The following is a description of a gene set: studied in species Homo sapiens Human Gene Set: GOBP_POSITIVE_REGULATION_OF_AMYLOID_BETA_FORMATION Any process that activates or increases the frequency, rate or extent of amyloid-beta formation., and this is the list of marker genes: IFNG, PICALM, IFNGR1, GSAP, APOE, MIR206, SP1, CHRNA7, ABCA2, ROCK2, RELA, CLU, LRRTM3, CASP3, CSNK1E, TNF, EPHA4, GSK3A, EFNA1, SLC2A13, ABCG1